The following is a description of a gene set: Genes predicted to be targets of miRBase v22 microRNA mmu_miR_3059_5p in miRDB v6.0 with MirTarget v4 prediction scores > 80 (high confidence targets). studied in species Mus musculus from publication Chen Y, Wang X (PMID 31504780) Mouse Gene Set: MIR_3059_5P, and this is the list of marker genes: Mlx, Dnmt3a, Slc10a4-ps, Tfdp2, Nalf1, Usp34, Ptgr1, Erbb4, Stam, Stxbp5l, Lrp4, Cnr1, Hk2, Pknox2, Utrn, Zfp521, Lin52, Sdc3, Dio2, Psd3, Ntng1, Slc8a1, Ndrg2, Rbfox1, Alcam, Nrg3, Slc25a53, Asb3, Zpld1 (zona pellucida like domain containing 1), S2bpcox16, Adam22, Cntn3, Ythdc2, Cdkn2d, Cdh2, St8sia4, Cntrl, Niban1, I830077J02Rik, Gria3, Zfp606, Tmem167, Arsj, Adgra2, Cox16, Vav2, Sec14l4 (NCBI Gene Id 216512), Foxj2, Grik3, Cplx4, Mdn1, Zcchc24, Runx1t1, Sgip1, Fbn2, Pdzk1, Septin4, Rnf13 (ring finger protein 13), Rbm41, Atp8b2, Dpysl2, Traf3, Igf2bp2, Ss18, Ednrb (endothelin receptor type B), Pnoc, Tmem248, Enpp2, Aplf, Agap1, Ankrd17, Sema3g, Vps54, Srp72, Pcdhb3, Kcnd3, Zpbp, Ric1, Dapp1, Esyt3, Ppfia2, Olfm3, Adal, Lrpprc, Igsf9b, Dlgap2, Lhfpl6, Pomt2, AI429214, Sgk3, Sh3pxd2a (SH3 and PX domains 2A), Fam20b, Zfp768, Herpud2, Mbnl1, Vwc2l, Dgkg, Mmp16, Slc43a1, Osbpl9, Top1, Ppp1r1c, Acss3, Zfp772, Isl1, Fam210a, Pradc1, Zic2 (NCBI Gene Id 57066), Kcmf1, Jade1, Rap2c, Frmd4b, Treml2 (triggering receptor expressed on myeloid cells-like 2), Fam240b, Marchf3, Sema5a, 1700025G04Rik, Slc6a1, Csf2rb2, Sgtb, Gcm1, Synj2bp, Ankrd69, Plxdc2, Pdcl, Doc2a, Gsk3b, Hmgxb4, Tspan2, Rnf32 (ring finger protein 32), Taok1, Smad5, Atmin, Ppp1r3e, Usp38, Wdr77, Celsr2, Sohlh1, Fzd4, Fam43a, Zfp874b, Ppm1l, Gucy1a2, Ddr2, Bnc2, Med13l, Tfdp1, Shprh, Zfp944, B3gntl1, Cxxc4, Fzd1 (NCBI Gene Id 14362), Celf4, Zscan25, Gbp4, Entrep3, Tmem183a, Rfx7, Klhl6, Adamts18 (NCBI Gene Id 208936), Igfbp5, Emd, Arhgef33, Igtp, Pde3a, Sim1, Mapk10, Bicd1 (NCBI Gene Id 319962), Shoc2, Pcnt, Cdk19, Rbfox2, Fst, Kbtbd11, Kcnb1, Etv1, Ankrd28, Samd4, Pde12, Ankrd44, Vcl, Dcaf5, Plekha3, Cmya5, Dao, Otulinl, Pabpn1, Jag1, Bhlhe22, Brinp1, Gtf2a1, Cdh11, Sall1, Pikfyve, Zfand3, Pigg, Ebf1, Eef1a2, Lama5, Ildr2, Fbxl14, Zfp329, Kdm4c, Chst2, Alg10b, Gabrg1, Rap1gds1, Mob1b (MOB kinase activator 1B), Golga4, Ces2e, Maco1, Rab7, Zfp324, Six4, Fgfr3, Mapre1, Btn2a2, Emc3, Ptprb, Cldn8